Given this list of marker genes Grm1, Lgi2, Paqr5, Shisa7, Psd2, Lmtk3, Prdm13, Neil2, Tmem151b, Dll3, Cbln1 (cerebellin 1 precursor protein), Klhl40, Scn8a, Kcnk15, P4ha3, Lhx5, Pgf, Rasgef1c (NCBI Gene Id 74563), Rab6b, Slc6a1, Adcy7, Kcnc4, Scube2, Asic2, Aebp1, Fam43b, Lyzl4 (lysozyme-like 4), Wnt10b, Asic4, Ihh, Vstm4, Gabrd, Nfatc1, Dlgap2, L1cam, Hoxd12, Wnt2b, Nell2, Lrtm2, Myod1, Nefh, Hsd11b2, Slc6a2, Col9a2, Npas3, Ankrd63, Ptf1a, Nkx2-5 (NK2 homeobox 5), Plppr5, Sctr, Gabbr2, Dok6, Fndc5, Nalf1, Efna2, Sez6l, Gdnf, Slc35f3, Rspo4 (R-spondin 4), Slc34a2, Sdk2, Kcnq4, Pou2f3, Adra2c, Nrg3, Atp2b2, Cacna1i, Sim2, Foxe3, Skor1, Mmd2, Stk32c, Rprml, C1ql1, Gnb4, Nphs2, Hoxd8, Nptx2, Prom2, Cldn7, Mafb, Fgf3, Hs3st6, C1ql4, Necab2, Slc30a10, Fstl4, C1ql2 (NCBI Gene Id 226359, complement component 1, q subcomponent-like 2), Fev, Pdlim2, Nkx6-2, Efcc1, Tbx21, Myrip, Lmx1a, Bex2, Sh3rf3, Emx1, Nrxn2, Epha8, Chat, Epb41l3, Wscd2, Hoxc9, Slc18a3, Scrt1, Fam83f, Dio3, Cacna2d2, Hoxc10, Pde1b, Ntsr2, Drd5, Kdf1, Lhx3, Aff3, Adgrb2, Nell1, Vstm2l, Scn5a, Tcerg1l, Lmx1b, Scnn1b, Foxb2, Lamp5, Kcnh6 (potassium voltage-gated channel, subfamily H (eag-related), member 6), Coro2b, Uncx, Atp8a2, Nkd1, Slc2a13, Myo16, Kcnc3, Dhh, Mycbp2, Trim58, Kcna2, Doc2b, Cyp46a1, Atp2b3, Gsx2, Phyhipl (NCBI Gene Id 70911), Timp2, Itga2, Fibcd1, Foxc2, Cckbr, Abcg4, Grp, Col13a1, Kcnt1, Trnp1, Wnt7b, Brsk2, Dpysl4, Nkx2-4, Ltk, Fam163a, Mixl1, Grip1, Gabra5, Arx, Ccn3, Afap1l1, Cacna2d3, Ptprb, Lgi3, Rrad, Htr7, Panx2 (NCBI Gene Id 406218), Dock3, Ank1, Phf24, Kcnma1, Fgf5, Syt10, Hs3st2, Grb10, Six2, Syt16 (NCBI Gene Id 238266), Gabra4, Irx4, Grid2ip, Ntsr1, Crlf1, Ephb1, Gm266, Insrr (NCBI Gene Id 23920), Adamts18, Clstn2, Clgn, Nog, Acvrl1, Krt7, Htr6 (5-hydroxytryptamine (serotonin) receptor 6), Ecel1, Slc6a7, Chrna3, Ascl2, Hoxd11, Slc47a2, Tmem215, Podxl2, Syndig1l, Drd4, Irf8, Zic1, Evx2 (even-skipped homeobox 2), Nptxr, Dscam, Scn4b, Fezf2, Bhlhe23 (NCBI Gene Id 319514), Trhde, Dbn1, Tmem59l, Fbxo41 (F-box protein 41), Bmp2, Alox12, Foxf1, Neurog3, Pacsin1, Nkx2-3, Ptpn5, Pax2, Serinc2, Zfp804a, Otop3, Syt2, Rab11fip4, Rbp4, Rasl10b, Jazf1, Ache, Slc6a17, Jhy (NCBI Gene Id 70989), Gjb6, Rbfox3, Fgf12, Zbtb16, Cpne5, Tmem54, Abcc8, Sema7a, Dysf, Elfn2, Rtn4r, Gldc, Ajm1, Hoxd9, Lbx1, Pcnx2, Aifm3, Tbx5, Dmrt3, Matn4, Irf5, Rassf4, Cck, Stmn3 (stathmin-like 3), Aqp5, Slc32a1, Bhlha9, Hbq1b, Hhipl1, Hoxd4, Cnnm1, Rspo1, Kcnh2, Camk2b, Il1rl2, Htr1d, Sstr5, Dbndd1, Pfdn4, Hcrtr1, Neurod1, Itpka, Bsn, Ccdc92b, Drgx, Oxtr, Grin3b, Cimip2c, Sptbn2, Wnt3a, Nhlh2, Lrrc75b, Onecut3, Grid1, Comp, Tmem30b, Ptgis, Stum, Ace, Tmem91, Vsx2, Aire, Crhr1, Fzd10, Ak5, Prmt8, Grin2c, Hmx1, Skap1, Prlhr, T, Adgrb1, Ramp1, Wscd1, Pde4dip, Slc38a3, Foxd3, Qrfpr (pyroglutamylated RFamide peptide receptor), Slc35d3, Ablim3, Wdr86, Gdf7, Bcan, Sstr1, Nkx3-1, Insl3, Cdh22, Kcnh1 (NCBI Gene Id 16510), Syt6, Lhfpl3, Nkd2, C1qtnf4, Mmp9, Kcnq1, Vsx1, Alox12b, Batf3, Asic1, Sox1ot, Cxcl14, Irx1, Fbll1, Bmp6, Chd5, Sfrp5, Pde8a, Celf4, Cacna1g, Trp73, Foxe1, Far2, Kcns2, Slc6a5, Tcte1, Slc8a2, Oaf, Pcdhac2 (protocadherin alpha subfamily C, 2), Gfra3, Reln (reelin), Shh, Disp3, Apln, Cacna1d, Jph3, Chrdl2, Acan, B3galt5, Emilin3, Rasl12, Scube1, She, Kl, Draxin, Slc9a3, Neurog1, Kcnq2, Barx1, Slc18a2, Fam83g, Rims4, Pdx1, Tgfbi, Dnmt3l (DNA methyltransferase 3-like), Slit2, Hba-x, Col8a2, Cyp24a1, Adamts2, Bik, Spon1, Rax, Pth2, Slit1, Fgf8, Clmp, Tmem178, Tdrd6, Gal, Pgap6, Mycl, Ccdc184, Ebf4, Zfp641, Kcnd3, Igsf21, Lmo1, Fam184a, Kcnj4, Nkx6-1, Lamc3, Gm4793 (NCBI Gene Id 215714), Cartpt, Hes5, Cacng4, Adora2a, Elovl3, Cabp7, Slitrk3, Gbx1, Ttc9b, Alox15, Tmem132e, Kcnq3, Slc7a10, Col15a1, Vgll2, Cntn2, Gata5, Ptprt, Ybx2, Nxph2, Ntrk3, Pyy, Dpp10, Gata4, Adgra2, Chrnb2 (NCBI Gene Id 11444), Chad, Tfap2e, Aldh1a3, Hoxc12, Gria2, Tc2n, Pou3f3, here is a description of the gene set: species: Mus musculus Genes with high-CpG-density promoters (HCP) bearing the tri-methylation mark at H3K27 (H3K27me3) in MCV6 cells (embryonic fibroblasts trapped in a differentiated state). Mouse Gene Set: MIKKELSEN_MCV6_HCP_WITH_H3K27ME3 from publication Mikkelsen TS, Hanna J, Zhang X, Ku M, Wernig M, Schorderet P, Bernstein BE, Jaenisch R, Lander ES, Meissner A (PMID 18509334) Somatic cells can be reprogrammed to a pluripotent state through the ectopic expression of defined transcription factors. Understanding the mechanism and kinetics of this transformation may shed light on the nature of developmental potency and suggest strategies with improved efficiency or safety. Here we report an integrative genomic analysis of reprogramming of mouse fibroblasts and B lymphocytes. Lineage-committed cells show a complex response to the ectopic expression involving induction of genes downstream of individual reprogramming factors. Fully reprogrammed cells show gene expression and epigenetic states that are highly similar to embryonic stem cells. In contrast, stable partially reprogrammed cell lines show reactivation of a distinctive subset of stem-cell-related genes, incomplete repression of lineage-specifying transcription factors, and DNA hypermethylation at pluripotency-related loci. These observations suggest that some cells may become trapped in partially reprogrammed states owing to incomplete repression of transcription factors, and that DNA de-methylation is an inefficient step in the transition to pluripotency. We demonstrate that RNA inhibition of transcription factors can facilitate reprogramming, and that treatment with DNA methyltransferase inhibitors can improve the overall efficiency of the reprogramming process.